Given this list of marker genes GNB2, RYR2, TBX5, KCNA5, SCN1B, LRP12, KCNH2 (NCBI Gene Id 4027), KCNQ1, TRDN, CASQ2, GJA5, CSRP3, PRKAG2, KCNE2, SCN5A, SCN2B (sodium voltage-gated channel beta subunit 2), ABCC9, LMNA, PLN, SCN3B, KCNJ2, HCN4, MYL4, here is a description of the gene set: studied in species Homo sapiens Human Gene Set: HP_PAROXYSMAL_ATRIAL_FIBRILLATION Paroxysmal atrial fibrillation Episodes of atrial fibrillation that typically last for several hours up to one day and terminate spontaneously.